Given this list of marker genes FPR2, PADI1, KLHDC8B, SLC39A14, OPN3 (NCBI Gene Id 23596), CABLES1, RNF128, CDCA8, TBL2, HYLS1, GPI, CDK18, SLC39A4 (NCBI Gene Id 55630), GPR150, SMAD9, NR4A3, GPAA1, ZHX3, ALOX5, E2F7, CENPT, ANKRD13B, METTL21A, BEX2, NPVF, TMEM237, MTFR2, HROB, KNL1, GPATCH3, SKA2, VEZT, TSC22D4, CCNE1, ATP5F1B, TPI1, SCIN, OLFM4, MAD1L1, IMPA2, IL4R, RSPH1, CCDC127, BUB1B, NREP, GALE, LGALS3, CENPM, RHOA, ERCC6L, PCLAF (PCNA clamp associated factor, NCBI Gene Id 9768), COQ3, UBE2A, MLEC, RAPGEF5, FAM72A (NCBI Gene Id 729533), KIF2C, NDUFA1, ATP2A3, SNRPA, CLSPN, IGF2BP2 (insulin like growth factor 2 mRNA binding protein 2), TAL2, ARHGDIB, SMPD4, CAPZA3, ASB8, C11orf24, EFHD2, SLC19A1, ATCAY, CMSS1, ACTG1, SOX5, TREM2, KAT2A, SPRING1, VEGFA, MAZ, POLE, CNOT3, ACOD1, H2AX, TSPOAP1, HTRA4, SCLY, C3, SYT5, EIF1AD, APEX1, CCAR2, BCAT1, PCED1A, SH3PXD2B, HMGXB3 (NCBI Gene Id 22993), GPX1, COQ4, TP53, UBE2V1, F2RL2, CD9, MPST (mercaptopyruvate sulfurtransferase), SPC24, RBM15B, LDHA, RAD54L, LRRC75B, TST, PPA1, GGT1, CDC34 (cell division cycle 34, ubiqiutin conjugating enzyme), YARS1, ICA1, COTL1, CA4, TICRR, FTH1, LAMP1, IGFLR1, AKAP1, FPR1, KPNA2, HGFAC, C19orf12, TXNRD1, NDUFB7, DSC1, MMEL1 (NCBI Gene Id 79258), SKI, SUV39H1, B3GAT3, SSNA1, CHCHD10, SLC1A5, MTSS1, DNAJB12, LZIC, RAN (RAN, member RAS oncogene family), ARHGDIA, FANCE, MPP4, HRAS, MATN3, RAB7A, TAGLN2, HOMER3, CEP89, ZCWPW2, SUCLG1, CLEC5A, HSD17B7, CSNK2B, GSTM5, PTK7, SLC16A13, HBEGF, TACC2, S1PR4, CD320, FRMD6, RNASEH2C, PIMREG, AEN, ECE2, GOT2, CPT1C, LGALS1, NOMO1, KCNN3, SIDT2, PPP6R2, SLC25A38, BAMBI, CFP, METTL1, GSTM4, ILF2, MCF2L, PGAP3, ALDOA, CHEK1, FABP5, UBE2QL1, HDAC6, RANBP1, METRN, ASF1B, COX8A, IQGAP3, KCNC3 (NCBI Gene Id 57363), SLC39A2, CLUH (clustered mitochondria homolog), PSRC1, CKAP4, C3orf18, PWWP2B, HOPX, AP2M1, LRRTM1, DCTPP1 (NCBI Gene Id 79077), here is a description of the gene set: from publication Yamagata T, Benoist C, Mathis D (PMID 16623764) studied in species Homo sapiens Genes down-regulated in B lymphocytes: B2 versus B1. Three innate (B1-B, NKT, CD8aaT cells) and adaptive (B2-B, CD4T, CD8abT cells) cell-types were sorted by FACS. Three biological replicates for NKT, CD4T, CD8aaT, CD8abT cells and two biological replicates for B1 and B2 cells were generated and the expression profiles were determined using Affymetrix Mu74Av2 chip. Comparisons between the sample groups allow the identification of genes differentially expressed between the innate and adaptive cell-types. Human Gene Set: GSE3039_B2_VS_B1_BCELL_DN